Given this list of marker genes ABCC5, B3GNT7, PRKACG, PCK1, CHST5, RAE1, SGSH, GALM, PGK1, TPI1 (triosephosphate isomerase 1), SEH1L, B4GALT5, B3GALT1, GYS1, B4GALT3, HS6ST1, MAN2B1, NHLRC1, LYVE1, DSE (NCBI Gene Id 29940), PHKA2, RPIA, CHST11, NUP93, DSEL, B4GALT6, G6PC2, GUSB, PRKACB, CSGALNACT1, HK3, ST3GAL2, FUT3, FUT2, HGSNAT, EXT1, SDC3, PFKFB3, KERA, HAS3, GPC4, MAN2B2, GLCE, GLB1L, FUT9, HYAL3, NDST4, GNPDA2, MAN2C1, HS3ST5, GCK, PAPSS1, CHST1, TALDO1 (transaldolase 1), HK1, NUP205, NUP160, CSPG4, FMOD, DCXR (dicarbonyl and L-xylulose reductase), AAAS, CALM1, PRELP, PPP2CB, PRPS1, HS3ST3B1, CHSY1, B3GAT1, LALBA, HSPG2, HPSE2, PGM2L1, CHST12, ENO4, PGD, G6PC1, UBC, BCAN, SDC4, AGL, PFKFB2, NUP54, HEXB, PFKFB4, ALDOC, FUT5, SLC37A4, EXT2, NUP58, PKLR (NCBI Gene Id 5313), DERA, OGN, GNPDA1, ST3GAL6, CRYL1, XYLT2, FBP1, B4GAT1, ST3GAL1, PHKG2, POM121C, EPM2A, HS2ST1, B3GNT4, B3GNT3, KHK, PFKP, VCAN, HS3ST4, RHD (NCBI Gene Id 6007), PFKL, B3GALT6, STAB2, PYGB, CHST6, FUT4, PPP2R1A, UBB (NCBI Gene Id 91253), SDC2, NUP50, GPC5, CEMIP, HKDC1 (hexokinase domain containing 1), B4GALNT2, B4GALT4, RANBP2, NUP153 (NCBI Gene Id 9972), PYGL, HK2 (NCBI Gene Id 3099), GBE1, NDST3, BGN, B3GALT2, NUP188, NCAN, AGRN, NUP107, SLC35B2, GLB1L2, CHST3, CHSY3, PHKB, NUP133, B4GALT7, SLC26A2 (solute carrier family 26 member 2), LUM, HAS1, B3GALT5, ST3GAL4, GPC6 (glypican 6), GPI, NDST1, SLC9A1, HS3ST6, NUP210, CHST9, SHPK, PFKFB1, GALT, DCN (NCBI Gene Id 1634), GAPDH, HS6ST3, HS3ST2 (NCBI Gene Id 9956), CHP1, HMMR, PGAM1, PPP2CA, GYG2, NUP42, RHCE, GLB1L3, PC, SLC35B3, NUP43, PHKG1, ENO1, PGLS, NAGLU (NCBI Gene Id 4669), HEXA, TKT, PRKACA, UBA52, NUP214, NUP155, HYAL1, GALNS, OMD, FUT7, XYLT1, HS3ST3A1, CHST15, NUP62, SDC1, B3GALT4, ADPGK, GAA, XYLB, B4GALT2, PAPSS2, NDC1, GALK1, NUP98 (nucleoporin 98 and 96 precursor), PYGM, RBKS, ALDH1A1, PCK2, RPS27A (ribosomal protein S27a), G6PC3, HYAL2, PPP1R3C, ALDOA, CHST14, GPC3, TKFC, B3GAT3, NUP85, MANBA, UST, ARSB, ST3GAL3, SLC35D2, GLYCTK, ALDOB (aldolase, fructose-bisphosphate B), IDS, NUP35, CHST13 (carbohydrate sulfotransferase 13), HS6ST2 (NCBI Gene Id 90161), GPC2, ST6GALNAC6, CSPG5, G6PD, CHPF2, PGAM2, NUP37, PFKM, ENO2, RPE, AKR1A1, CSGALNACT2, SLC37A2, PPP2R1B, GYG1, CHST7, ACAN, SLC2A1, GYS2, CHPF, POM121, UGP2, FBP2, PHKA1, SEC13, IDUA, CD44, RPEL1, GAPDHS, GCKR, B4GALT1, SLC37A1, B3GNT2, GALE, FUT6, UXS1, GNS, PGK2, NDST2, PGM2, AKR1B1, PKM, HAS2, PGM1, PRPS2, FUT1, BPGM, SORD, B3GAT2, GPC1, ENO3, PRPS1L1, AKR1E2, TPR, NUP88, HPSE, CHST2, GLB1 (galactosidase beta 1), HS3ST1 (heparan sulfate-glucosamine 3-sulfotransferase 1), PPP2R5D, SLC26A1, here is a description of the gene set: species: Homo sapiens Metabolism of carbohydrates and carbohydrate derivatives Human Gene Set: REACTOME_METABOLISM_OF_CARBOHYDRATES_AND_CARBOHYDRATE_DERIVATIVES